The following is a description of a gene set: Human Gene Set: HP_LIMITED_HIP_MOVEMENT A decreased ability to move the femur at the hip joint associated with a decreased range of motion of the hip. species: Homo sapiens Limited hip movement, and this is the list of marker genes: COMP, CHST3, ERI1, EXT1, FILIP1, TPM2, PIEZO2, DST, DVL1, EXT2, KY, COL2A1, NIPA1 (NIPA magnesium transporter 1), TTN (NCBI Gene Id 7847), MATN3, GPC6, TNNT1, TRPV4, PTH1R (parathyroid hormone 1 receptor), ZMPSTE24, NFIX, LMNA, FGFR3, DYSF, HGD